Given this list of marker genes PRRX1, PPP1R15B, GPR101, CAMTA1, WBP11, FREM2, MEGF8, PAFAH1B1, TCTN3, AVP, KCNH1, IFT80, TOGARAM1, RAB23, ZNF341, PTEN, IL11RA, SATB2, WLS, GRIP1, HDAC4, CDH11, DONSON, FHL1, TWIST2, VPS33A, MAN1B1, SMARCA2, COX7B, TRMT10A, ACBD6, NOTCH2, ATP6V1B2, LARP7, AIP, KATNB1, PHGDH, BUB1, ARID1A, TBL1XR1, TONSL, NDE1, RELN, RNF2, MGP, SMARCB1, LMX1B, TRIM37, ACTB, TMCO1, GPC4, DLK1, DYNC2I2, FRAS1, SLC37A4, FGFR1, IDS (iduronate 2-sulfatase), ACY1, FZD2, DVL1 (NCBI Gene Id 348497), STXBP1, POR, SIN3A, STAMBP, WNT5A, COG7, TRIP13, OTUD6B, BRCC3, CRLF1, MOGS, CKAP2L, HMGA2, KIF11, PIGG, LMBRD2, BUB1B, HCCS, DYNC2I1, RNF125, QRICH1, INTS11, RAI1, SMG9, ADAMTS18, WDR35, KMT2D, RTL1, YWHAE, INSR, IDUA, KCNN3, SKIC3, FUCA1, CRELD1, RPS6KA3, CEP57, KAT6B, ESCO2, ACTG1, DVL3 (NCBI Gene Id 1857), POU4F1, SETBP1, PPP1CB, SETD1A, TBX1 (T-box transcription factor 1), NANS, CCNQ, TAF4, COG8, PAM16 (NCBI Gene Id 51025), LEMD3, GDF5, NDUFB11, CLCF1, DPF2, CHD8, KMT2A, DYNC2H1, SEC23A, EPG5, BUB3 (NCBI Gene Id 9184), MEG3, ASPH, SMARCA4, KDM6A, STAT3, VPS53, SMARCE1, ALG12, here is a description of the gene set: Human Gene Set: HP_WIDE_NOSE studied in species Homo sapiens Interalar distance more than two standard deviations above the mean for age, i.e., an apparently increased width of the nasal base and alae. Wide nose